Given this list of marker genes ANXA2, LDLR, GRIA1 (NCBI Gene Id 2890), NSF, RAB29, ACHE, KIF16B, ARAP1, OPTN, CHMP5 (charged multivesicular body protein 5), TRAT1, AP1AR, NSG1, PSEN1, BVES, EPS15, PCSK9, LAMTOR1, RAMP3, TBC1D16, VAMP3, SNCA, ECE1, SCRIB, INPP5F, here is a description of the gene set: Human Gene Set: GOBP_REGULATION_OF_RECEPTOR_RECYCLING Any process that modulates the frequency, rate, or extent of receptor recycling. studied in species Homo sapiens